The following is a description of a gene set: Cerebellar hemisphere hypoplasia Human Gene Set: HP_CEREBELLAR_HEMISPHERE_HYPOPLASIA species: Homo sapiens, and this is the list of marker genes: TSEN34, PTRH2, PRDM13, LAMB1, MACF1, ZNF335, SON, B4GAT1